Given this list of marker genes KRT18, NR4A1, DARS1, CDH1, CTSL, LGALS3, WARS1, SAT1, SARS1, FOXC1, CLK1, GLRX, TRIP6, SYBU, ENO2, DLX4, EIF1, GARS1 (NCBI Gene Id 7972), here is a description of the gene set: Down-regulated genes associated with the acquision of metastatic potential in LNM35 cells (large cell lung cancer). from publication Tomida S, Yanagisawa K, Koshikawa K, Yatabe Y, Mitsudomi T, Osada H, Takahashi T (PMID 17260014) Human Gene Set: TOMIDA_METASTASIS_DN Although widespread metastasis is the major cause of human lung cancer-related deaths, its underlying mechanism remains largely unclear. Our genome-wide comparison of the expression profiles of a highly metastatic lung cancer cell line, NCI-H460-LNM35 (LNM35), and its parental clone, NCI-H460-N15 (N15), resulted in the identification of a cancer metastasis signature composed of genes. Through gene ontology analysis, our study also provided insights into how this 45-gene metastasis signature may contribute to the acquisition of metastatic potential. By applying the signature to datasets of human cancer cases, we could demonstrate significant associations with a subset of cases with poor prognosis not only for the two datasets of cancers of the lung but also for cancers of the breast. Furthermore, we were able to show that enforced expression of the DLX4 homeobox gene, which was identified as a gene with significant downregulation in LNM35 as well as with significant association with favorable prognosis for lung cancer patients, markedly inhibited in vitro motility and invasion as well as in vivo metastasis via both hematogenous and lymphogenous routes. Taken together, these findings indicate that our combined transcriptome analysis is an efficient approach in the search for genes possessing both clinical usefulness in terms of prognostic prediction in human cancer cases and clear functional relevance for studying cancer biology in relation to metastasis. studied in species Homo sapiens